Given this list of marker genes POLR1B, ITGA7, LIMK1, SMAD3, NEDD4L, MECP2, SCN4A, EDA, WNT10A, RFC2, TCOF1, GNAQ, WDR35, ANKH, PIGS, LOX, MKKS, PLEKHM1, SSR4, GLI2, ENAM, GPR68, HMGB3, KLK4, ITPR1, IL6ST (interleukin 6 cytokine family signal transducer), TBC1D2B, IFT74, NKX6-2, POLR1C, IRX5, EP300, PIGK, LRP6, BPTF (NCBI Gene Id 348241), MASP1, LARP7, EDARADD, ZEB2, NARS1, SELENON, AHDC1, RAP1B, FGFR2, NOTCH2, TBL1XR1, FKBP6, BBS1, NXN, BANF1, NCF1 (neutrophil cytosolic factor 1), ANKRD11, CLIP2, CHSY1, DSPP, ERCC6, CHRNE, PTEN, PIGL, SH3PXD2B, GRHL3, COL3A1, KCNN3, NPHP1, BBIP1, NECTIN1, UBE3A, CEP19, STX1A, DNAJC30, POLR1D, TWIST2, GTF2IRD1, SMCHD1, SUMO1, HNRNPH1, ARSK, RPS6KA3, BMP2, FAM83H, CCDC47, LRP5, BBS2, DRG1, CDC42BPB, NAA80, CDC42, HIVEP2, IL1RAPL1, KDM1A, ALX3, SMARCA2, SIX1, ADAMTS15, NHS, GNAS, MAN2B1, FGFR3, TTI2, TAF4, ADAMTS10, SNX14, RPL10 (ribosomal protein L10), ATR, SMAD2, RUNX2, PTPN11, STAG1, OFD1, DLX4, PRKACA, RDH11, RAI1, SOS1, ZNF526, SMC3, PEX6, DSE, PIK3CA, MADD, KCNH1, ADAMTS2, BBS12, RNU4-2, CLP1, COL1A2, FGF3, GALNS, ITGB6, TMEM270, CBS, MED12, DOCK7, INSR, PCYT1A, UBE3B (NCBI Gene Id 89910), DPM2, CHRNG, CDH1, SCARF2, TUBGCP2, CUL4B, POLR2A, MAP3K7, BRCA1, BAZ1B, GPR101, CHST3, NSDHL, RIC1, KDM5C, DVL3, GPC3, EDN1, WNT5A (NCBI Gene Id 7474), C12orf57, TOMM7, GRB10 (growth factor receptor bound protein 10), PTH1R, BMP4, GLB1, PORCN, SDCCAG8, CNTNAP2, TP63 (NCBI Gene Id 8860), NAA20, KIF15, GJA1, PDGFRA, PRMT7, DLX3, ZSWIM6, IFT43, OCRL, TRIM37, TRIM32, DPH1, ADNP, ZDHHC9, CERT1, ARHGAP29, WDPCP (WD repeat containing planar cell polarity effector), OBSL1, DCHS1, MYMX, TTI1, LZTFL1, COBLL1, KCNJ2, CEP295, EDNRA, THOC6, UPF3B, PRKAR1A, TTC8, TECPR2, NONO, IRF6, GNAI3, FGFR1, ATP6V1E1, B3GLCT, AEBP1, AGO2, SATB1, LTBP3, ACTL6B, PACS2, SH3BP2, RAB3GAP2, BCAS3, PCGF2, TCIRG1, SKI, PLCB4, SETBP1, GJA8, GUSB, BRAF, PSMD12 (proteasome 26S subunit, non-ATPase 12), LIG4, SCLT1, CEP290, IFT57, IFT122, PIK3R1, ARL6, ABCC9, EIF4H, KDM6A, TAF6, PRR12, TRIO, AIP, MEGF8, EMC10, CFAP418, KIAA0753, BBS7, PTPRF, ACP4, MAP2K1, TBL2, MMP20, MSX1, KCNMA1, EIF2S3, SATB2, DPH2, CAMK2B, ROR2, H4C5, COL5A1, PIGA, NOTCH3, RHOA, FAT4, CDK19, MYOD1 (NCBI Gene Id 4654, myogenic differentiation 1), MLXIPL, RNF2 (NCBI Gene Id 6045), SOST, FLNA, AXIN2, ATP6V1B2, MGAT2, RECQL, H19, FREM2, XYLT1, RNF113A, ALKBH8, ERCC4, METTL27, HRAS, PAX9, ARHGEF38, KATNB1, TBC1D24, SCAPER, AMER1, SMC1A, IFT52, NIPBL, ACP5, TCF12, GFPT1, MKS1, PPP1CB, CDK5RAP2, ZFX, BAP1, ASPH, FLCN, MED13L, FZD2, DOCK3, TCF4, LMNA, SETD5, TRPS1, DHCR7, HACD1, ABL1, PACS1, HK1, ERCC8, FGF10, NAA10, IL11RA, MYL2, SOBP, NSUN2, DDR2, CNOT2, OCA2, WDR26, GTF2I, RHOBTB2, CA2, FGD1, CREBBP, HDAC8, HNRNPK, DNMT3A, CDH3, SPEN, KANSL1, KCNJ5, NDST1, LMBRD2, EYA1, WBP4, PAX1, NECTIN4, TPM3, ATRX, LGI4, GPC4, BBS4, TBCD, BBS9, TPM2, TBX4, PRKD1, WNT10B, POLD1, TSPAN7, TGFA, GTF2IRD2, ACVR1, TANC2, BCOR, BBS5, SMS, HDAC4, PUS7, AIMP2, ZMPSTE24, PLOD1, FREM1, ELN, AFF3, RAB3GAP1, MTM1, ERCC1, MAP3K20, SNRPN, SET, EXOSC5, SETD1A, SLC39A13, SMARCD2, AMELX, DVL1, DDX59, CTSK, XRCC4, CDH11, DLG1, AMMECR1, CHD3, MAPK1, SCUBE3, BBS10, RELT, SHANK3, IFT140, GNB2, KIDINS220, CCDC28B, MBD5, TWIST1, KMT2D, SPART, MARS1, CLCN7, BUD23, USP9X, MYH3, IFT27, HSPG2, ACTA1, ALX4, IFT172, PDE4D, GJA5, FRAS1, VPS37D, GATAD2B, PYROXD1, SPECC1L, RAD21, ASXL3, IGF2, MED27, EFEMP1, RLIM, FBN1, ZBTB7A, SMC5, BRD4, IDS, BRF1, GRIP1, DYRK1A, SOX5, here is a description of the gene set: Tooth malposition species: Homo sapiens Human Gene Set: HP_TOOTH_MALPOSITION Abnormal alignment, positioning, or spacing of the teeth, i.e., misaligned teeth.